The following is a description of a gene set: species: Homo sapiens Human Gene Set: GOBP_KETONE_CATABOLIC_PROCESS The chemical reactions and pathways resulting in the breakdown of ketones, a class of organic compounds that contain the carbonyl group, CO, and in which the carbonyl group is bonded only to carbon atoms. The general formula for a ketone is RCOR, where R and R are alkyl or aryl groups., and this is the list of marker genes: CYP4F3, KYAT1, NQO2, HSD17B6, CYP4F8, GATD1, PARK7, PNKD, KYAT3, CYP4F11, ALDH8A1, CYP4F12, HAGH (NCBI Gene Id 3029), CYP4F2, CBR3, OXCT1, KYNU